Given this list of marker genes Aoc1, Aoc1l3, Odc1, Aoc1l1, Agmat, Azin2, Sat1, Azin1, Paox, Ldc1, Sat2, Aoc1l2 (NCBI Gene Id 69761), here is a description of the gene set: The chemical reactions and pathways involving putrescine, 1,4-diaminobutane; putrescine can be formed by decarboxylation of ornithine and is the metabolic precursor of spermidine and spermine. Mouse Gene Set: GOBP_PUTRESCINE_METABOLIC_PROCESS studied in species Mus musculus